The following is a description of a gene set: Mouse Gene Set: GOBP_POSITIVE_REGULATION_OF_TYPE_2_IMMUNE_RESPONSE studied in species Mus musculus Any process that activates or increases the frequency, rate, or extent of a type 2 immune response., and this is the list of marker genes: Gata3, Prkcz, Il4, Xcl1, Il4ra, Rsad2, Clcf1, Il33, Nlrp3, Ido1, Cd74, Cd81, Dennd1b, Nod2, Il6, Tnfsf4, Rara, Il18